The following is a description of a gene set: studied in species Homo sapiens Human Gene Set: WP_17P133_YWHAE_COPY_NUMBER_VARIATION 17p13.3 (YWHAE) copy number variation, and this is the list of marker genes: YWHAB, YWHAE, YWHAQ, DCTN4, NDEL1, CDK5, DCTN3, DYNC1H1, YWHAZ, TH, YWHAG, PAFAH1B1, PPP2CA, DDC, DCTN5, DCTN2 (dynactin subunit 2), DCTN1, DBH, DCTN6, DISC1, YWHAH